The following is a description of a gene set: Human Gene Set: GOBP_REGULATION_OF_NUCLEAR_TRANSCRIBED_MRNA_CATABOLIC_PROCESS_NONSENSE_MEDIATED_DECAY Any process that modulates the frequency, rate or extent of nuclear-transcribed mRNA catabolic process, nonsense-mediated decay. studied in species Homo sapiens, and this is the list of marker genes: SECISBP2, UPF3A, CASC3, APOBEC1, EIF4A3, PABPC1, DHX34, A1CF, SYNCRIP, NBAS, RBM8A, MAGOH, MAGOHB, HNRNPAB